The following is a description of a gene set: Human Gene Set: GOBP_U4_SNRNA_3_END_PROCESSING Any process involved in forming the mature 3' end of a U4 snRNA molecule. studied in species Homo sapiens, and this is the list of marker genes: EXOSC3 (exosome component 3), EXOSC9, EXOSC2, EXOSC5, EXOSC6, EXOSC8, EXOSC7, EXOSC4